The following is a description of a gene set: electronically inferred by orthology from the curated human pathway This event has been computationally inferred from an event that has been demonstrated in another species.<p>The inference is based on the homology mapping from PANTHER. Briefly, reactions for which all involved PhysicalEntities (in input, output and catalyst) have a mapped orthologue/paralogue (for complexes at least 75% of components must have a mapping) are inferred to the other species. Reactome Pathway: G beta:gamma signalling through BTK studied in species Mus musculus part of: G-protein beta:gamma signalling, and this is the list of marker genes: Gng10, Gngt2, Gng8, Gnb5, Gng7, Gng3, Gng4, Gng5, Gnb2, Gngt1 (guanine nucleotide binding protein (G protein), gamma transducing activity polypeptide 1), Gng11 (guanine nucleotide binding protein (G protein), gamma 11), Gnb3